The following is a description of a gene set: A cellular senescence process associated with the dismantling of a cell as a response to environmental factors such as hydrogen peroxide or X-rays. Mouse Gene Set: GOBP_STRESS_INDUCED_PREMATURE_SENESCENCE studied in species Mus musculus, and this is the list of marker genes: Pla2r1, Sirt1, Wnt16, Bmal1, Mapk14, Mapkapk5, Trp53 (NCBI Gene Id 22059)